Given this list of marker genes CYP2E1, IDO1, IDO2, CYP1B1, AADAT, GSTM3, GSTM4, FAH, AFMID, EPHX2, SRD5A2, GSTM1, KMO, ACSM1, KYNU, TDO2, ALDH8A1, ACAA1, HAAO, KYAT3, GSTM2, KYAT1, CYP4B1, here is a description of the gene set: The chemical reactions and pathways involving benzene, C6H6, a volatile, very inflammable liquid, contained in the naphtha produced by the destructive distillation of coal, from which it is separated by fractional distillation, or any of its derivatives. Human Gene Set: GOBP_BENZENE_CONTAINING_COMPOUND_METABOLIC_PROCESS studied in species Homo sapiens